Given this list of marker genes HNRNPD, VDAC3, UBAP2L (ubiquitin associated protein 2 like), RHEB, AFG3L2, SLC1A5, SERP1, PDIA6, MCM7, ACP1, SF3A2, H2AZ1, SNRPA1, TEX261, NCBP2, TYMS, NUDT1, CCT5, MSH2, CYCS, DDX39B, DUT, DYNLL1, DNAJC9, UBE2S, ATXN10, FH, RBMX, CSNK2B, KHDRBS1, G3BP2, NAA10, TOMM70, HSPE1, PCNA, DDX49, VDAC1, KHSRP, CHAF1A, DNMT1, NCL, PSMD8, CHERP, IDH3G (NCBI Gene Id 3421), GNB1 (NCBI Gene Id 87729), CCT7, FUS, MRPL9, TARS1, COPS5, RBBP4, GNG5, HADH, SOD1, PTPN11, MCM6, NDUFS3, ZWINT (NCBI Gene Id 11130), HDDC2 (HD domain containing 2), USP1, ATP5MC1, PRPF8, RNPEP, DKC1, PPP1CC, PRDX3, SRSF1, CS, DGUOK, SRSF9, DEK, VDAC2, RSL1D1 (ribosomal L1 domain containing 1), EIF2S2, YWHAQ, TARDBP, IMPDH1, DAP3, DDOST, SMC1A, GANAB, PHB2, POM121, MTCP1, PPIE, UBA2, SDHA, BAG6, SRSF3, LSM2, PRKDC, HNRNPM, LRPPRC, RUVBL2, SSB, GOT2, SNRPA, FBL, UBE2N, HNRNPR, PSMB7, HNRNPC (heterogeneous nuclear ribonucleoprotein C), HAX1, ATP5MC3, MCM3, LSM4, RFC4, EIF1AX, TUFM, ACLY, CCT3, TXNL4A, ACTL6A, HAT1, SAFB, CLPP, RRM1, PAICS, LSM7, AP3S1, PCLAF, STMN1, GTF2A2, AK2, TMED9, HNRNPU, MRPS18B, NSDHL, ATP5PO, IMMT (inner membrane mitochondrial protein), SMC3, EDC4, CTDNEP1, METAP1, IFRD1, EIF4EBP2, SET, HDAC1, TFDP1, NDUFS4, SNRNP200 (NCBI Gene Id 692221), ERP29, SF3B2, TRIM28, PRPS2, PTGES3, XPO7, NDUFS5, R3HDM1, ILF2, PPT1, NUDC (nuclear distribution C, dynein complex regulator), CBX3, DDX19B, SRRM1, PSMB2, ATP5F1D, LYPLA1, MAP2K2, NDUFC1 (NADH:ubiquinone oxidoreductase subunit C1), RAN, SCAMP3, PABPC4, TUBA3C, SLC25A3, NAE1, MDH1, KXD1, ESD, HSPA9, EIF4H, AURKB, GMPS, NDUFB3, DCTD, MTREX, TRAPPC3, PDHB, GPN1, ANP32B, BRD8 (NCBI Gene Id 10902), UBE2L3, GLO1, PPM1G, HNRNPAB, NSD2, RAD23A (RAD23 homolog A, nucleotide excision repair protein), HCCS, SDHB, PRPF31, MAPRE1, SSRP1, SLBP, NONO, DOCK3, YARS1 (tyrosyl-tRNA synthetase 1), ANP32A (NCBI Gene Id 8125), TAF11, TCP1, NUP188, EIF3I, ICE1, HNRNPA2B1, EPRS1, IARS1, CALM3, VBP1, SSBP1, BAZ1B, UQCRC1, U2AF1, IPO7, CYC1, XPO1, NDUFS2, ATP5F1A, CAD, CCT2, SREBF2, ANAPC5, NDUFV1, LMNB2, DNAJC8, AATF, SNRPE, POLE3, MRPS27, PPP2R1A, GARS1, XRCC5, HADHA, RPA2, IMPDH2, EI24, EIF3K, ATP5PF, POLA2, MTDH, FEN1, THOP1, NASP (NCBI Gene Id 96573), CAPZA1, BUB1, H2AZ2, TCEA1, XRCC6, CSK, MCM2, MCM5, POLR2I, SERBP1, DRG1 (developmentally regulated GTP binding protein 1), FIBP, PMEL, PTDSS1, STARD7, DARS1, AHSA1, SRM, XPOT, DNAJC11, HDAC2 (NCBI Gene Id 3066), NRDC, ESPL1, HNRNPUL1, ILF3, AKR7A2, KARS1, TNPO3, HCFC1, STK24 (NCBI Gene Id 8428), UQCRH (NCBI Gene Id 7388), CDK2, RANGAP1, PARK7, BUB3, SEC24C, here is a description of the gene set: Human Gene Set: MORF_BUB3 Neighborhood of BUB3 Neighborhood of BUB3 BUB3 budding uninhibited by benzimidazoles 3 homolog (yeast) in the MORF expression compendium studied in species Homo sapiens